The following is a description of a gene set: Human Gene Set: GOBP_REGULATION_OF_INFLAMMATORY_RESPONSE_TO_WOUNDING Any process that modulates the frequency, rate or extent of the inflammatory response to wounding. species: Homo sapiens, and this is the list of marker genes: GRN, GIT1, IL17A, ALOX5, EXTL3, DSG2, MIR21, REG3A, MDK, PTPN6 (NCBI Gene Id 5777), STAT3 (NCBI Gene Id 6774), SIGLEC10, IL33